Given this list of marker genes IL12A, CIB2, SCN1A, LHFPL5, CLCNKB, TRDN, SLC39A14 (solute carrier family 39 member 14), TWNK, RNF170, GPR156, NKX2-6, TPK1, PTPRQ, CEACAM16, GAS2 (growth arrest specific 2), KCNQ1, SDHD, SCN2B, FOXI1, TMEM132E, ARSG, GATA2, NR0B1, MED12, GJA5, MYL2, SDHAF2, PTPN22, COL3A1, ESRP1, PDGFB, SLC1A3, BCOR, PNPT1, NF2, SLC26A4, DNM1, CALM1, IL23R, GABRB3, RARA, ERAP1, RYR2, CATSPER2, DKK1 (dickkopf WNT signaling pathway inhibitor 1), MYL4, SCD5, USH1C (NCBI Gene Id 80102), NPM1, OTOGL (otogelin like), GCDH, RFC1, KCNJ2, USH1G, KCNE1, NABP1, NPPA, STAT4, CACNA1A, TLR4, PDE1C, GJB6, TP53, MAX, CALR, GJB2 (NCBI Gene Id 2706), CD164, NOP56, ATP1A2, NKX2-5, CALM3, TRPM4, VHL, NUMA1, ABCC9, NUP155, SH2B3, KCNJ10, THPO, VSX1, BRAF, FH, SUFU (NCBI Gene Id 51684), MAPK10, CNNM2, SDHB, PLS1, MEN1, IL10, MVK, COCH, KARS1 (NCBI Gene Id 3735), CLRN1, CALM2, SLC12A3, KCNQ2, MPL, GJB3, ESPN, SLC17A8, CDH23, KCNJ5, OTOG, PKHD1L1, PPIP5K2, KCNE2, RYR1, SLC9A1, ELMOD3, FXN, MYD88, LRTOMT (NCBI Gene Id 613203), ALMS1, ZBTB16, SCN1B, GATA5, CCND1, SCN2A, POLG, FAS, NARS2, MLX, FGF14, DBH, JUP, IRF2BP2, MCM2, RET, DMXL2, C4A, MT-TS2, KLRC4, TTN, SOX6, TNC, STAT3, THOC1, ATXN3, GRXCR1, CCDC50, CHD2, SCN5A, AIFM1, PRKAR1A, UBAC2, CEP78, GRXCR2, WHRN, PDZD7, TMC1, GYG1, AIP (NCBI Gene Id 9049), MDH2, TET2, GATA4, CCR1, GLA, GCGR, TNFRSF1A, SLC25A11, IL12B, TECRL, CASQ2, SDHC, MEFV, PML, KCNJ3, KIF1B, NF1, FLI1, PCDH15, KCNA5, IL12A-AS1, FIP1L1 (NCBI Gene Id 81608), CLIC5, HLA-DRB1, CACNB4, LOXHD1, TIMM8A, HLA-B, GIPC3, KCNA1, HARS1 (histidyl-tRNA synthetase 1), NAGA, ADA2, LRP4, CACNA1G, CLRN2, MYO6, SCN3B, EPAS1, STRC, CTNNB1, JAK2, STAT5B, JAG1, CRYM, PRRT2, SDHA, IFNGR1, PITX2, DNMT3A, STX4, CUX2, GATA6, TMEM127, SRPK3, P4HA2 (prolyl 4-hydroxylase subunit alpha 2), DLST, MYO7A, TBL1XR1, RIPOR2, TBC1D24, EPOR, ATP2B2, SCN4B, here is a description of the gene set: studied in species Homo sapiens Abnormal vestibular function Human Gene Set: HP_ABNORMAL_VESTIBULAR_FUNCTION An abnormality of the functioning of the vestibular apparatus.